The following is a description of a gene set: Mouse Gene Set: GOCC_TRANSCRIPTION_FACTOR_TFIIIC_COMPLEX A heterotrimeric transcription factor complex that is involved in regulating transcription from RNA polymerase III (Pol III) promoters. TFIIIC contains three conserved subunits that associate with the proximal Pol III promoter element, and additional subunits that associate with sequence elements downstream of the promoter and are more diverged among species. It also functions as a boundary element to partition genome content into distinct domains outside Pol III promoter regions. studied in species Mus musculus, and this is the list of marker genes: Gtf3c6, Gtf3c5, Gtf3c3, Gtf3c1, Gtf3c2, Gtf3c4